The following is a description of a gene set: part of: Cell surface interactions at the vascular wall Reactome Pathway: PECAM1 interactions studied in species Homo sapiens PECAM-1/CD31 is a member of the immunoglobulin superfamily (IgSF) and has been implicated to mediate the adhesion and trans-endothelial migration of T-lymphocytes into the vascular wall, T cell activation and angiogenesis. It has six Ig homology domains within its extracellularly and an ITIM motif within its cytoplasmic region. PECAM-1 mediates cellular interactions by both homophilic and heterophilic interactions. The cytoplasmic domain of PECAM-1 contains tyrosine residues which serves as docking sites for recruitment of cytosolic signaling molecules. Under conditions of platelet activation, PECAM-1 is phosphorylated by Src kinase members. The tyrosine residues 663 and 686 are required for recruitment of the SH2 domain containing PTPs., and this is the list of marker genes: YES1, ITGAV, LCK, INPP5D, FYN, SRC (SRC proto-oncogene, non-receptor tyrosine kinase), ITGB3, PECAM1, PTPN11, PLCG1, PTPN6, LYN